The following is a description of a gene set: Human Gene Set: GSE17721_CTRL_VS_POLYIC_24H_BMDC_UP mouse primary BMDCs were stimulated with tlr ligands and gene expression changes were profiled on Affymetrix arrays from publication Amit I, Garber M, Chevrier N, Leite AP, Donner Y, Eisenhaure T, Guttman M, Grenier JK, Li W, Zuk O, Schubert LA, Birditt B, Shay T, Goren A, Zhang X, Smith Z, Deering R, McDonald RC, Cabili M, Bernstein BE, Rinn JL, Meissner A, Root DE, Hacohen N, Regev A (PMID 19729616) studied in species Homo sapiens Genes up-regulated in comparison of control dendritic cells (DC) at 24 h versus those stimulated with poly(I:C) (TLR3 agonist) at 24 h., and this is the list of marker genes: XPC, MEPCE, CROT, COX16, HEATR5B, XBP1, KCNK13, FUCA2, ARID4B, ZC3H14, MRPL48, PNO1, KIF13A, FLNA, SOX4, AHCTF1, IPPK, ENPP1, MAP3K12, CD177, SMPDL3A, ASGR2, RPL13, DLD, YAE1, HDAC6, ACLY, SETDB1, SSR4, ANLN, CEACAM21, SCAMP1, CD81, FKBP9, FERRY3, NDUFB2, QRSL1, CASP6, MINDY1 (MINDY lysine 48 deubiquitinase 1), SMC3, APBB1IP, CLEC4F, HERC4, RAB7A, LTC4S, SLF1, UNC5C, PFN1, ADCY8, EMC2, PDYN, PPP1CC, GSTO1, RPL31, TESK2, GTF2B, TSHZ1, MYOZ1, RPL28, RNASE4, ZDHHC6, CREB3L3, CRYZ, TMEM38B, ARHGAP17, NTHL1, ARHGDIB, EFL1 (NCBI Gene Id 79631), PIMREG, CCNB2, DAG1, HSCB (HscB mitochondrial iron-sulfur cluster cochaperone), BEX3, CUL4B, LTBR, TP53INP2, TMEM147, CLNS1A, MIX23, MYL12B, AAAS, ARPC1A, ATP5ME, MEF2A, HADH, EBP, NEDD8, ARHGAP6, CPE, FAF1 (NCBI Gene Id 112268262), UCP2, NHLH1, HPRT1, RARG, SUPT4H1, CD300C, MCEE, DNM3, PES1, IFT80, RHBDD3, MRPL51, RPLP1, POU6F1, FAM111A, CPPED1, MCUB, PDCL, NUCB2, ELOVL5, PARK7, OMD, KHK, NSMF, PALD1, KLHL9, PRKAG1, SRF, BCAP29, SLC39A4, CIITA, SQLE, TPK1, RCSD1, NEK7, ZIC4, HTR1D, RPL6 (ribosomal protein L6), ADK, MUC1, ERMP1, MYO5A, LZTR1, OGG1, BCL2L11 (NCBI Gene Id 150819), WBP11, POGLUT2, PIK3C2A, RPL41, CA12, CENPQ, ABCG2, GSR, RFC1, RARS2, C19orf48P, TOMM20, RGS10, CTSA, RNF187, FANCG, LIMD2, KRT10, KIAA1143, CCNA2, NEFH, STIM1 (stromal interaction molecule 1), SLC47A1, NDUFV2, EEF1AKMT1, AKR1B1, SCN2A, HGSNAT, PRKRA, CHURC1, GCG (NCBI Gene Id 2641), CISD1 (NCBI Gene Id 55847), PIP4K2A, PPP1R18, SLC35A5, UBXN8, PDK4, TMEM50B, TMEM242, PRKCH, NUCB1, AIFM1, TALDO1, MATR3, KBTBD2, BACH2, PHPT1, HAS3, RPS15A, ACOT13, ATRAID, ABI1, ADCY2, S100A1, ELOVL6, ANXA6, HAUS4, EDEM3, SPSB2, ASCC1, TNFAIP8, ALDOA, TCEAL9, SKP1